The following is a description of a gene set: A transcription factor complex that acts at a regulatory region of a gene transcribed by RNA polymerase III. Human Gene Set: GOCC_RNA_POLYMERASE_III_TRANSCRIPTION_REGULATOR_COMPLEX studied in species Homo sapiens, and this is the list of marker genes: BDP1, GTF3C2, GTF3C6, GTF3C4, GTF3C3, GTF3C1, BRF2, GTF3C5, BRF1